Given this list of marker genes DSE (NCBI Gene Id 29940), CHST14, PLOD3, PIEZO2, AUTS2, here is a description of the gene set: Decreased palmar creases Poorly defined or shallow palmar creases. species: Homo sapiens Human Gene Set: HP_DECREASED_PALMAR_CREASES